The following is a description of a gene set: DNA copy number amplifications activate oncogenes and are hallmarks of nearly all advanced tumors. Amplified genes represent attractive targets for therapy, diagnostics and prognostics. To investigate DNA amplifications in different neoplasms, we performed a bibliomics survey using 838 published chromosomal comparative genomic hybridization studies and collected amplification data at chromosome band resolution from more than 4500 cases. Amplification profiles were determined for 73 distinct neoplasms. Neoplasms were clustered according to the amplification profiles, and frequently amplified chromosomal loci (amplification hot spots) were identified using computational modeling. To investigate the site specificity and mechanisms of gene amplifications, colocalization of amplification hot spots, cancer genes, fragile sites, virus integration sites and gene size cohorts were tested in a statistical framework. Amplification-based clustering demonstrated that cancers with similar etiology, cell-of-origin or topographical location have a tendency to obtain convergent amplification profiles. The identified amplification hot spots were colocalized with the known fragile sites, cancer genes and virus integration sites, but global statistical significance could not be ascertained. Large genes were significantly overrepresented on the fragile sites and the reported amplification hot spots. These findings indicate that amplifications are selected in the cancer tissue environment according to the qualitative traits and localization of cancer genes. Human Gene Set: MYLLYKANGAS_AMPLIFICATION_HOT_SPOT_6 from publication Myllykangas S, Himberg J, Böhling T, Nagy B, Hollmén J, Knuutila S (PMID 16751803) species: Homo sapiens Amplification hot spot 6: colocolized fragile sites and cancer genes in the 17p13-p11.1 region., and this is the list of marker genes: TP53, PER1, FLCN, RABEP1, SPECC1 (sperm antigen with calponin homology and coiled-coil domains 1), MAP2K4 (NCBI Gene Id 6416)